Given this list of marker genes DSC3, FURIN, NFAT5, GPC4, ITGA4, NENF, RPS6KA4 (ribosomal protein S6 kinase A4), ENTPD7, RBMX, REST, COIL, KCNK10, MAGEB6, MFAP3L, RNF128, FUBP1, TRIM36, LMO3, TBC1D8, CNTLN, ZDHHC21, MARK3, TBC1D9, RAB8B, FZD1, AGFG1, CD5L, PLEKHA3, RPS6KA5, ERG28, PDLIM5, CKAP2, CETN2, SDC2, ZFYVE21 (zinc finger FYVE-type containing 21), USP46, ARMC8, PHLPP2, SPOCK1, OSBPL8, GKAP1, NPAT, MIER1, KIF23, SACS, DDHD1, PPP1R1A, ACER3, STIM2, L3MBTL1, TRIP10, SMIM13, F3, CSRNP3, FGD5, PCDH20, STMN1, IFRD2, DNAJC27, SCN1A (NCBI Gene Id 6323), NBEAL1, FBXL5, TRIM33, PLCH1, FAM76B, C2CD2, GOLPH3, PHIP, ZFYVE26, MKRN1, AQP4, YWHAQ, TMCC3, PEX5L, MAP3K2, KLHL15, NDNF, KRT10, IFI44L (interferon induced protein 44 like), GPR6, MPDZ, CEP44, STRN, RCOR1 (REST corepressor 1), PTPN4, DENND5B, ATG16L1, EGLN3, RBM12B, NEDD4, FZD4, ADAM10 (NCBI Gene Id 102), TNRC6B, ZNF800, PPP2R3A, TMEM68, GPR137B, RAD21 (RAD21 cohesin complex component), TNFRSF21, DPP8, MAGOHB, EGR3, KRTAP4-7, RASD1, NTRK3, ADAMTS5, RNF38, VASP, RNASE9, CHRM2, SPAG9, INIP, AAK1 (NCBI Gene Id 652453), NBR1 (NCBI Gene Id 9740), FLRT3, CEP97, ZNF850, IKZF2, ANKRD33B, FBXL3, KGD4, DPP10, AMPD3, PPP3CA, ASTN2, GMDS, FAM168A, TYRP1, ENPP5, GNAI1, FSD1L, PDGFC, IL6ST, PCDHA1, PRKAR2B, B3GALNT2 (beta-1,3-N-acetylgalactosaminyltransferase 2), RAMAC, ZNFX1, PHTF2, GXYLT1, ADAM22, NT5E, WDCP, EP300, ELK3, PDE7B, KDM3B, RBSN, FRMD6, PPP1R15B (protein phosphatase 1 regulatory subunit 15B), FEM1C, C3orf70, TES, YOD1, MYT1L, KCNE4, HERC1, LRFN5, DCTN6 (dynactin subunit 6), FAM117B (NCBI Gene Id 65069), HMGB2, ZFHX4, UBASH3B, BZW1, COBL, EXOSC5, TRIM13, DOCK7, NRIP1, SCD, TXNIP, DNAJC15, CYB561D1, KMT5B, SLC35A5, CCND1, SLAIN2, EZH1, VASH2, TMEM245, TDRD6, DOCK4, CNGB3, GIPC2, SCAI, ACOX3, TMEM168, FUNDC2, SLC46A3, SLCO1C1, SLCO4C1, ETV1, CDC25A, MYLIP, ANO6, BCL2L11, STRIP2, OSMR, TMEM71, SH3PXD2A, BICC1, AHI1, MMP13, SLC36A1, PBLD, PRICKLE2, LRP12, TMEM255A, ARHGAP26, BRMS1L, USF3, AMELX, SLC24A2, RASGRF2, NRIP3, NIBAN2, POU2F1, EPAS1, LAMA3, LYPLA1, MAPRE3, IL12A, PPM1A, SETD2, MAP3K20, RARB, FNBP4, TNFSF13B, GRIP1, MED17, KCNAB1, BRWD3, ZFYVE9, FAM120A, RASL11B, CDIN1, MAN1A2, LRRK1, BMP2K, ADGRL3, KCNB1, SLC39A8, MRPS25, FZD3, CCSAP, AKR7A2, SLC16A7, PRKD3, NRG3, E2F5, SSH2 (NCBI Gene Id 85464), MTF1, PRKCH, SERTM1, PDK4, XIAP, HIVEP3, AKAP11 (NCBI Gene Id 79988), FOXJ3, KLHL2, TMEM9B, SHTN1, DUSP2, LEPROT, NDUFA5, CXCL5, BCAT1, ITGB8, LITAF, AVIL, TOX, CITED2, ST8SIA3, HSPA8, TMEM128, EIF4A2, JPT1, UTP23, PTDSS1, COX7A2, RUNX1, BTG2, TRIP11, ZBTB20, VANGL1, MASTL, RAP2C, UGCG, NSD2, TNC, UBE2D1, REV3L, GPR63 (G protein-coupled receptor 63), PIK3C2A, SGMS2, FRS2, RAPH1, PDE5A, TRPC1, SMARCA5, EML1, EPHA4, MATN3, SMG1, ANO5 (anoctamin 5), HNRNPL, PLPPR1, MCF2L2, CMBL, MED12L, CD36, BTG3, GRM5, RRAGD, PRR15, SPSB4, SLC31A2, MAGI3, SLC4A7, MTMR10, NASP, AP3D1, PLPPR5, BTG1, OTUD4, RXFP1, ACTR2, CLOCK, C12orf75, MED13, ADD1, YY1, LAMP3, RYK, BTF3L4, NEUROD1, DCDC2, PKD2, CLEC12A, GPN3, UNC5D, YWHAB, MARCHF6, SH3GL3, GUCY1A2, RRAS2, TOX3, ITGB1, NAP1L5, HIBCH, SCAND3, ZNF514, here is a description of the gene set: species: Homo sapiens Genes predicted to be targets of miRBase v22 microRNA hsa-miR-3609 in miRDB v6.0 with MirTarget v4 prediction scores > 80 (high confidence targets). Human Gene Set: MIR3609 from publication Chen Y, Wang X (PMID 31504780)